Given this list of marker genes PLIN2, PILRA (NCBI Gene Id 29992), EGLN3, TMEM45A, HLA-DQA2, S100A11, C15orf48, TPI1, MXI1, IFI6, ENO2, TUBGCP2, STX8, ADAM8, VCAN, TIMP1, HEBP1, GPNMB, LDHA, CTSD, IFITM3, LGALS3 (galectin 3), ZNF385A, S100A6, NUPR1, GABARAP, TREM1, P4HA1, SLC2A3, SLC6A8, FCER1G, GATM, SPP1, BEX3 (brain expressed X-linked 3, NCBI Gene Id 27018), SLAMF9, MIF (macrophage migration inhibitory factor), TNS1, TMIGD3, IL1RN (NCBI Gene Id 3557), RNASE1, RPS27L, FBP1, ADM, TMEM91, PELATON, TMEM51, ARPC3, HK2 (NCBI Gene Id 3099), GLUL, C4orf3, HCST, BNIP3, MAD1L1, MYL6, APOC1, LSM3, BNIP3L, ENO1, ANG, LY96, LGALS1, EIF4EBP1, LSP1, GAPLINC, IL4I1, FCGR2B, CLEC5A, TYROBP, HILPDA, SLC2A1, RGCC, RNASET2, ATF5, GAPDH, LYZ, RALA, FTL, ARPC5, PLTP, TGFBI (transforming growth factor beta induced), SLC2A5, NDRG1, PRR13, MACROH2A1, ERO1A, LY6E, GPI, NCF2, BLVRB, FAM162A, TMEM140, here is a description of the gene set: studied in species Homo sapiens The transformation of benign lesions to malignant tumours is a crucial aspect of understanding chondrosarcomas, which are malignant cartilage tumours that could develop from benign chondroid lesions. However, the process of malignant transformation for chondroid lesions remains poorly understood, and no reliable markers are available to aid clinical decision-making. To address this issue, we conducted a study analysing 11 primary cartilage tumours and controls using single-cell RNA sequencing. By creating a single-cell atlas, we were able to identify the role of endoplasmic reticulum (ER) stress in the malignant transformation of conventional central chondrosarcomas (CCCS). Our research revealed that lower levels of ER stress promote chondrosarcoma growth in a patient-derived xenograft mouse model, while intensive ER stress reduces primary chondrosarcoma cell viability. Furthermore, we discovered that the NF-?B pathway alleviates ER stress-induced apoptosis during chondrosarcoma progression. Our single-cell signatures and large public data support the use of key ER stress regulators, such as DNA Damage Inducible Transcript 3 (DDIT3; also known as CHOP), as malignant markers for overall patient survival. Ultimately, our study highlights the significant role that ER stress plays in the malignant transformation of cartilaginous tumours and provides a valuable resource for future diagnostic markers and therapeutic strategies. Human Gene Set: SU_HO_CONV_CENT_CHONDROSARCOMA_LEUKOCYTE_C1_M2_MACROPHAGE from publication Su Z, Ho JWK, Yau RCH, Lam YL, Shek TWH, Yeung MCF, Chen H, Oreffo ROC, Cheah KSE, Cheung KSC (PMID 38267611) Characterized by FCGR2B, FCGR3A, SLC2A1, and SPP1, and expressed a lower level of cytokine and chemokine and showed adaptation to a hypoxic environment. Monocyte lineage marker CD68 was universally expressed.